Given this list of marker genes KCNH2, ANK2 (ankyrin 2), KCNE2, HCN4, SCN1B, CACNA1G (calcium voltage-gated channel subunit alpha1 G), ACE, CTNNA3, CAMK2D, KCNQ1, KCNJ3, CACNA1C, CACNB2, KCNE4 (NCBI Gene Id 23704), YWHAE, SCN5A, TRPM4, KCNE1, SCN4B, KCNE5, SCN2B, KCNE3, CACNA2D1, SCN3B, JUP (NCBI Gene Id 3728), DSG2, BIN1, HCN1, DSC2, CACNA1D, AKAP9, SRC, KCNJ2, CAV1, ISL1, GJA5, KCNJ5, PKP2, HCN3, DSP, KCNA5, KCNH6, KCND3, here is a description of the gene set: species: Homo sapiens A cardiac conduction process that modulates the frequency or rate of heart contraction. Human Gene Set: GOBP_REGULATION_OF_HEART_RATE_BY_CARDIAC_CONDUCTION